Given this list of marker genes GEMIN4, ANAPC1, LBR, ZMPSTE24, GNAS, GALNT3, LMNA, STX16, CASR, RECQL4, AGXT, here is a description of the gene set: Calcinosis species: Homo sapiens Human Gene Set: HP_CALCINOSIS Formation of calcium deposits in any soft tissue.